The following is a description of a gene set: Any ubiquitin ligase complex in which the catalytic core consists of a member of the cullin family and a RING domain protein; the core is associated with one or more additional proteins that confer substrate specificity. Mouse Gene Set: GOCC_CULLIN_RING_UBIQUITIN_LIGASE_COMPLEX studied in species Mus musculus, and this is the list of marker genes: Klhl40, Pramel7, Pramel5, Kbtbd3, Pramel20, Dcaf1, Pramel42, Pramel60, Fbxl16, Pramel18, Fzr1, Klhl12, Pramel45, Spsb3, Cul9, Cdc20b, Pramel15, Pef1, Pramel39-ps, Fbxl7, Fbxl4, Asb17, Klhl38, Fbxl9, Pramel1, Oog4, Cop1, Cul2, Zswim5, Pramel17, Pnkp, Kbtbd12, Fbxl13, Fbxo17, Fbxl17, Pramel43, Cul1, Zyg11a, Klhl11, Fbxl22 (NCBI Gene Id 74165), Klhl18, Cdc16, Fbxo39, Pramel33, Pramel30, Spopl, Dcaf12l1, Pramel11, Pramex1 (NCBI Gene Id 75829), Dcaf4, Pdcd6, Zyg11b, Pramel26, Dcaf5, Anapc2, Klhl9, Anapc10, Klhl35, Pramel6, Cul7, Dcaf11, Ccnf, Klhl5, Fbxl6 (NCBI Gene Id 30840), Rnf7, Gm13040, Ivns1abp, Dcaf10, Klhl24, Anapc15-ps, Pramel36, Skp2, Spsb4, Pramel37, Tmem183a (NCBI Gene Id 75635), Klhl1, Socs7, Usp47, Anapc13, Fbxo44, Cdc26, Klhdc3, Pramel61, Spsb1, Asb11, Klhdc2, Pramel47, Fem1a, Fbxl14, Fbxw4, Ube2c, Fbxw11, Klhl22, Pramel31, Zswim6, Klhl13, Crbn, Pramel23, Pramel29, Anapc4, Cks1b, Pramel32, Kctd2, Zswim8, Ube2s, Asb4, Fbxo3, Dda1, Klhdc1, Asb9, Fbxl15, Pramel21, Klhl23 (NCBI Gene Id 277396), Spop, Cdc23, Klhl42, Wdtc1, Dtl, Kbtbd6 (NCBI Gene Id 432879), Pramel35, Cks1brt, Dcaf12l2, Cdc20, Pramel40, Fbxo31, Nccrp1 (non-specific cytotoxic cell receptor protein 1 homolog (zebrafish)), Kctd17, Tnfaip1, Pramel49, Klhl15, Arih2, Klhl30, Cand1, Fbxl21 (F-box and leucine-rich repeat protein 21), Pramel48 (PRAME like 48), Fbxo7, Eloc, Fbxl19, Pramel55, Fbxw7, Fbxo42, Anapc7, Ercc8, Fbxo32, Klhl8, Zer1, Fbxo45, Pcmtd1, Fbxl2, Klhl7, Fbxw5, Oog1, Fbxo24, Det1, Anapc1, Enc1, Fbxo27, Klhl2, Dcaf7, Ddb1, Gan, Fbxo9 (NCBI Gene Id 71538), Pramel57, Trim21, Kbtbd2, Mad2l2, Daw1, Dcaf6, Oog3, Dmac2, Pramel12, Pramel38, Cdc27, Anapc5, Rnf7l, Lztr1, Pramel22, Cks2, Btrc, Fem1al, Pramel59, Pramel56, Aurkaip1, Fbxl5, Trpc4ap, Klhl41, Ccin, Pramel16, Dcaf8l, Klhl3, Glmn, Elob, Kbtbd8, Cul5, Kctd13, Dcaf12, Commd1, Pramel51, Keap1, Katna1, Rbx1, Dcaf15, Pramel28, Klhl20, Fbxo6 (NCBI Gene Id 99978), Arih1 (ariadne RBR E3 ubiquitin protein ligase 1), Amn1, Pramel19, Skp1, Fbxo25, Vhl, Pramel24, Fbxo4, Klhl21, Trim63, Pramel13, Klhl17, Cul4b, Pramel53, Cul3, Fbxo15, Depdc5, Pramel46, Anapc15, Pramel41, Klhdc10, Ankrd9, Lrrc75a, Klhl6, Ddb2 (NCBI Gene Id 72138), Klhl25, Dcaf8, Cacybp, Pramel34, Anapc16, Oog2, Pramel25, Spsb2, Siah1a, Ube2srt, Fem1b, Fbh1, Dcaf17, Fbxo2, Fbxl18, Dcaf13, Wdr77, Pramel50, Fem1c, Anapc11, Pramel14, Ambra1, Pramel54, Klhl10, Cul4a, Appbp2, Kctd10, Fbxw8, Ipp, Fbxo48, Socs2 (suppressor of cytokine signaling 2), Cdkn1b, Klhl4, Kctd5, Rbx1-ps, Kbtbd7, Klhl29, Klhl28, Fbxl3, Zswim4, Fbxl20, Pramel27, Pramel44